Given this list of marker genes SRSF6, CRYBG1, IGKV1D-13, HPX, GGT1, NVL, CDK10, CDK12, BRINP3, GOT1, ABCC6, SLC37A1, MUC1, TMPRSS2, KMO, ALDH4A1, ERBB2, C2orf72, GRB7, TRAF4, PLPBP, CRISP2, PADI3, PRODH, LRP1, SCD (NCBI Gene Id 6319), S100A8, KYNU, SQSTM1, SCGB2A2, TSKU, FA2H, HMGCS2, IGLC2, SERHL2, IGKV1OR2-108, ACSL1, ABCC2, NQO1, ABCC3, ASPH, ANP32A, IGKV1D-39, IGHV3-7, SUPT6H, P4HB, BIK, IGKV3-20, KIAA0319L, PAPSS2, UBE2M, CLCA2, SPTLC2, GSE1, PPP1R10, UGT2B11, GALNT6, MPHOSPH6, SLC12A1, CD164, QPRT, BLTP2 (bridge-like lipid transfer protein family member 2), WIPF2, PSMD3 (NCBI Gene Id 94019), S100A9, SLPI, TMED2, ATP2C2, IGHV4-61, ALCAM, TM7SF2, MED1, AQP3, PGAP3, FFAR2, TFAP2B, S100A7, LDLR, APOD, TRPV6, CATSPERB, UCP2, FGG, MED24, LPCAT3, LAMA4, DUSP6, TMC5, ITGB6, IGKV4-1, FGB (NCBI Gene Id 2244), LRRC31, ALDH3B2, MMP15, ORM2, SEPTIN8, IGKV1D-17, AR, MAB21L4, NUDT4, PRMT7, EFNA3, PNMT, SERHL, PIP, WWC2, CD24P4, GSDMB, IGF2R (NCBI Gene Id 3482), FASN, ACE2, PLEKHA6, KRT24, CEACAM6, EPYC, TSPAN1, ABCA12 (NCBI Gene Id 3392), SEC24D, SLC2A10, SCNN1A, FUT3, CD46, LBP, CORO1B, DDC, SNPH, FAIM2, G6PD, TRIM3, SCGB1D2, IL13RA1, TRPM4, TSPAN8, RRP7A, SLC44A4, NOL3, STARD3, ASS1, EIF5A, CYB561, CPD, PEX11A, IGKV1D-37, AKR1B10, IGHV3-23, ELL2, GCAT, NCOA3, CRISP3, SRPK3, CAMP, CLIC3, here is a description of the gene set: Genes up-regulated in the erbb2 subype of breast cancer samples, characterized by higher expression of ERBB2. Human Gene Set: SMID_BREAST_CANCER_ERBB2_UP We explored whether the five previously reported molecular subtypes in breast cancer show a preference for organ-specific relapse and searched for molecular pathways involved. The intrinsic gene list describing the subtypes was used to classify 344 primary breast tumors of lymph node-negative patients. Fisher exact tests were used to determine the association between a tumor subtype and a particular site of distant relapse in these patients who only received local treatment. Modulated genes and pathways were identified in the various groups using Significance Analysis of Microarrays and Global Testing. Bone relapse patients were most abundant in the luminal subtypes but were found less than expected in the basal subtype. The reverse was true for lung and brain relapse patients with the remark that absence of lung relapse was luminal A specific. Finally, a pleura relapse, although rare, was found almost exclusively in both luminal subtypes. Many differentially expressed genes were identified, of which several were in common in a subtype and the site to which the subtype preferentially relapsed. WNT signaling was up-regulated in the basal subtype and in brain-specific relapse, and down-modulated in the luminal B subtype and in bone-specific relapse. Focal adhesion was found up-regulated in the luminal A subtype but down-regulated in lung relapse. The five major molecular subtypes in breast cancer are evidently different with regard to their ability to metastasize to distant organ(s), and share biological features and pathways with their preferred distant metastatic site. studied in species Homo sapiens from publication Smid M, Wang Y, Zhang Y, Sieuwerts AM, Yu J, Klijn JG, Foekens JA, Martens JW (PMID 18451135)